The following is a description of a gene set: Genes predicted to be targets of miRBase v22 microRNA hsa-miR-5699-5p in miRDB v6.0 with MirTarget v4 prediction scores > 80 (high confidence targets). Human Gene Set: MIR5699_5P species: Homo sapiens from publication Chen Y, Wang X (PMID 31504780), and this is the list of marker genes: SLC23A2, SARM1, CASQ1, LPCAT1, ULK3, CYTH3, ANKS1A, MSI2, EEF1AKMT2, WNK2, SIM2, PSMA4, ZFYVE21, ADAMTS17, TMBIM6, ERCC8, PPP3CB, DUOX1, ZNF396, ZHX1, SPTA1, AFTPH, TGFB3 (NCBI Gene Id 7043), JADE3, LRRC10B, SDC3, IL6R, SINHCAF, PABIR1, GOLGA2, TTLL11, GOPC, UBA6, HIPK2 (NCBI Gene Id 653052), CLCC1, MAGEB3, RDH11, NECAP2, TMEM242, PTPN14, KIF5A, PEX19, KLHL18, BRD2 (NCBI Gene Id 9803), CFAP97D1, BRD10, TRABD2B, YTHDC1, ZRANB2, ZBTB33, SEPTIN4, ZBTB14, LCP2, ACVR2A, XPO4, SUPT6H, OGA, TMEM164, PTPRU, OXR1, JOSD1, S1PR2, SYNE1, TENM3, INSR, CD96, TPH2, ZSCAN12, ARHGAP11A, TTC5 (NCBI Gene Id 91875), MYO9A, SCML2, FOXK2, ID4, LARGE1, MTM1, DCDC2, TESK2, IGF2BP1, RUSC2, BCL9, ZNF512B, SUN2, UBE4B (NCBI Gene Id 10277), NR3C2, JAK1, NEO1, SLC10A7, KBTBD4, CCPG1 (cell cycle progression 1), CREBZF, RSPRY1, ZNF780B, APBA1, ADAMTS14, STIP1, SHISA9, DYNC1LI2, HDGF, CHRND, ZC3H14, HIC2, RASSF6, GPATCH2L, CPLX3, ZNF528, PPP6R3, NAGA, OSBPL1A, PITPNM3, CAV2, FAM53A